Given this list of marker genes Slc17a3, Ralbp1, Slc22a18, Abcc1 (NCBI Gene Id 94110), Abcb1a, Slc47a2, Abcc2, Slc47a1, Abcg2, Abcb1b, Oscp1, here is a description of the gene set: A process that reduces or removes the toxicity of a xenobiotic by exporting it outside the cell. Mouse Gene Set: GOBP_XENOBIOTIC_DETOXIFICATION_BY_TRANSMEMBRANE_EXPORT_ACROSS_THE_PLASMA_MEMBRANE species: Mus musculus